Given this list of marker genes Bcl11b, Tfap2c, Fezf2, Nkx2-1 (NK2 homeobox 1), Zdhhc16, Lhx6, Tbr1, Dlx2, Smarcc2, Pax6, Ascl1, Dlx1, Gata2, here is a description of the gene set: The process in which the developmental fate of a cell becomes restricted such that it will develop into a neuron that resides in the forebrain. studied in species Mus musculus Mouse Gene Set: GOBP_FOREBRAIN_NEURON_FATE_COMMITMENT